Given this list of marker genes SP1, NFE2L2, CTNNB1 (NCBI Gene Id 1499), TCF7L2, PXYLP1, here is a description of the gene set: Human Gene Set: GOBP_POSITIVE_REGULATION_OF_SULFUR_METABOLIC_PROCESS Any process that activates or increases the frequency, rate or extent of the chemical reactions and pathways involving sulfur or compounds containing sulfur. species: Homo sapiens